Given this list of marker genes PDCD10, SMARCA4, ZFX, EDN2, PHF12, SERINC3, SORT1, OLFML2B, DST, IRX3, CSNK1G3, ZIK1, FOXE1, GABPB1, MED13L, MYCBP2, TM2D1, SALL1, EGLN1, SECISBP2L, HAS2, ENC1, MBNL1, EFNA1, U2SURP (NCBI Gene Id 23350), MOB4, ERF, AREG, PPFIA2, RAB11FIP3, DKK3, APOOL, IKZF2, KMT2C, PRR14L, RBM27, IRX5, TMF1, STRN4, MBNL2, HOXA10, RAD21, GATA3 (GATA binding protein 3), TRIM13, POLI, SLAIN2, PLSCR1, VNN1, TLE1, PTGFR, ADARB2, ZNF619, PIK3R4, ZNF570, FJX1, TRPC5OS, ZNF649, PHF20L1, MOSMO, GPR18, LRP6, USP25, RNF182, SLC7A11 (NCBI Gene Id 23657), ADAMTS5, PCDH20, SET, AP1S3, SLC30A5, KIAA1191, IPMK (inositol polyphosphate multikinase), PRDM16, PCLO, LEMD3, GNAQ, ARHGAP20, ENPP3, AKAP9, LMO1, TRAPPC4, PPP1R16B, RECK, KIF3A, ERCC3, UBE2O, LHX2 (NCBI Gene Id 9355), DYNC2LI1 (dynein cytoplasmic 2 light intermediate chain 1), RNF220, SPOCK3, BCL6, NRIP1, TCF7L2, GRHL3, BBX, TOB1, USP7, HOXC6, UBE3C (ubiquitin protein ligase E3C), EPHB4, IRX1, GABRB2, QKI, SLC35E1, CCR2, TLE4, IQGAP2, SSBP2, ZCCHC24, MAGI3 (NCBI Gene Id 57725), NADK2, PPP2CB, SGCG, DAZ3, ART3, WDR72, EEA1, EYS, DLX6, HMGB3, NUP133, NUP153, EPN2, GUCY1B1, SMOC1, SETD9, ROBO2, RBPMS, FBXO32, DEPDC7, ZSWIM6, BEND7, CIAO2A, ASAP2, GMCL1, BTBD3, TNFRSF11B, ELK4, VCAM1, ARAP2, TOR1AIP2, MPZ, PAFAH1B2, ITM2B, BMP7, LATS1 (NCBI Gene Id 9113), MYO1E, COL19A1, TIMP3, ANKS1A, GRIP1, SLC17A6, PLEKHG1, ASXL1, NRP1, FILIP1L, NAA20, LCOR, RAP1B, FLI1, DENND11, SFPQ, LSM14A, TSPAN12 (tetraspanin 12), RAPGEF5, MED23, CAGE1, MEF2D, RAB18, CSPP1, ARK2N, FRMPD4, LMO3, TVP23C, ENAM, PLXNC1, TASP1, FAM221A, BMPR2, GOLIM4, AKAP13, PIK3C2A, FGF13, GTF2I, CTTNBP2NL, RICTOR, CYP26B1, CASP8AP2, UBR1, ZNF326, ERAP1, LGR5, MAPK8, NUP160, ZNF830, MEOX2, RAB14, CAV2, PCSK2, SGCD, NCKAP1, PDE11A, TAMALIN, SEPTIN9, CBX3, RASA1, DOCK3, JAGN1, CXXC4, BACH2, FSTL5, OTX2, TENM1, RGS4, HSPE1-MOB4, SEC11C, FUT9, MMS22L, CERT1, TVP23B, C1orf52, PCDH17, SYN2, PTGER3, EYA4, INPP5B, SLC6A14, CCDC91, RORA (RAR related orphan receptor A), DCUN1D4, CPD, BAG2, PPP4R2, SATB1, NPAT, ITGA4, CNR1, SAMD4A, CALN1, TMTC2, NOTO, SFSWAP, DAZ2, WAC, DPP8, MAP2K4, HYCC2, IRF5, LIX1L, MDM1, ZNRF3, TMCC1, KHDRBS3, CBFA2T2, MTFR1, TFRC (transferrin receptor), GRIK4, SEMA3C, E2F6, BHLHE40, IQGAP1, HECTD2, TMEM209, DAZ1, UBE2H, PAH (phenylalanine hydroxylase), INO80D, CPEB2, VKORC1L1, ATXN3, CDKL3, HNRNPDL, FBXO34, ZC2HC1A, VCL, ARID1B, RC3H1, MTMR12, RANBP2, AKAP6, GABRA4, INSM1, DAZ4, HMGXB4, PNISR, SOX9, AAK1, SMARCA5, SPINK5 (serine peptidase inhibitor Kazal type 5), ZNF518A, BAZ1A (bromodomain adjacent to zinc finger domain 1A), GPHN, STXBP1, CNTN6, KLF3, SH3GL3, STARD13, MTHFD2L, RIPOR2, FOXF1, HVCN1, IRF2BP2, IAPP, MAPKAPK5, ATRX, DENND1B, CREBBP, LRCH4, ULBP1, CCDC186, EPG5, ANXA1, CFL2, PDE7A, SASH1, MS4A13, LANCL2, ARID4B, N4BP2, ARFGEF2, SLC2A13, TRMT1L (tRNA methyltransferase 1 like), DOCK11, NAA15, NUP98, DNAJB4, SMIM8, FOXO3, AXIN2, TRIO, RALGDS, CNTN3, SFMBT2, USP48, MTOR, ANP32A, MAP2, KLHL2, KIAA1217, RBM12B, HIPK3, GABRA1, FOXN2, FERMT2, HOXA9, JAG2, NXT2, ABL1, SLC8A1, DCP2, RAB2A, PDE10A, ZNF292, HSPA14, PUM2, RBL2, GCC2, LYSMD3, WDR82, PRR12 (proline rich 12), MBNL3, EBF3, DUSP6, ARAP1, LRP1B, PAK2, GP1BA, PLPP3, UBE2B, NASP, TGDS, MAP3K5, OTUD1, XIAP, RAB3GAP2, MON2, TCF3, BMPER, DDX21, GOLPH3L, DAGLA, NKTR, BEX4, PTPN3, KCNG3 (NCBI Gene Id 170850), SNX3, PSME4, USP32, TRIM61, ZNF441, TEK, TP53INP1 (NCBI Gene Id 94241), PCM1, TXLNG, GPR63, SLC22A10, ACSL3, CRISPLD1, ATP7A, TGFBR3, ZMYM6, CEP70, BRINP1, ASAH1, PHF3, TRAM1, KIAA0319, CREB5, TMEM132B, EYA1, here is a description of the gene set: Genes predicted to be targets of miRBase v22 microRNA hsa-miR-1185-1-3p, hsa-miR-1185-2-3p in miRDB v6.0 with MirTarget v4 prediction scores > 80 (high confidence targets). Human Gene Set: MIR1185_1_3P_MIR1185_2_3P from publication Chen Y, Wang X (PMID 31504780) studied in species Homo sapiens